The following is a description of a gene set: species: Homo sapiens Human Gene Set: GOBP_POSITIVE_REGULATION_OF_BEHAVIOR Any process that activates or increases the frequency, rate or extent of behavior, the internally coordinated responses (actions or inactions) of whole living organisms (individuals or groups) to internal or external stimuli., and this is the list of marker genes: STRA6, GRPR, SGIP1, ADORA2A, MTNR1B, OPRK1, CFAP20, NPS, UCN, MEF2C, AGRP, INSL5 (NCBI Gene Id 10022), NLGN1, VPS35, PENK, GHRH, GHRHR, GRIA1, HDAC2, NPAS2, NR4A3, CRH, GHSR, GHRL, RXFP4, GRP, MC1R, NPY2R, NPY